Given this list of marker genes HADHA, LDB3, REEP1, BICD2, MYH14, DYNC1H1, ATP9A, HADHB, FBLN5, PNPLA6, here is a description of the gene set: Decreased intensity of the patellar reflex (also known as the knee jerk reflex). Human Gene Set: HP_DECREASED_PATELLAR_REFLEX Decreased patellar reflex studied in species Homo sapiens